The following is a description of a gene set: Human Gene Set: HP_FRONTAL_UPSWEEP_OF_HAIR Upward and/or sideward growth of anterior hair. studied in species Homo sapiens Frontal upsweep of hair, and this is the list of marker genes: PWRN1, NPAP1, IFT140, CAMTA1, TRIO, MED12, MED13L, EP300, HDAC4, POLA1, UBAP2L, MED27, YY1, PIGA, OGT, CAMK2A, FOXP1, MAGEL2, FRMPD4, FBXO11, UBR1, MKRN3, CREBBP, BRD4, FLNA, SNORD115-1, TCF4, PPP2R3C, HERC2, SNORD116-1, PWAR1